The following is a description of a gene set: Increased overbite Human Gene Set: HP_INCREASED_OVERBITE Maxillary teeth cover the mandibular teeth when biting to an increased degree. The feature is defined as a vertical overlap of the maxillary incisors over the mandibular incisors that exceeds 2 mm. species: Homo sapiens, and this is the list of marker genes: SPART, ITPR1 (inositol 1,4,5-trisphosphate receptor type 1), GRB10, TAF4, RIC1, ALKBH8, EP300, HIVEP2, SIX1, ACP4, EYA1 (NCBI Gene Id 2138), MYMX, PRR12